The following is a description of a gene set: The process whose specific outcome is the progression of the mesendoderm over time, from its formation to the mature structure. In animal embryos, mesendoderm development gives rise to both mesoderm and endoderm tissues. Mouse Gene Set: GOBP_MESENDODERM_DEVELOPMENT species: Mus musculus, and this is the list of marker genes: Lhx1, Otx2, Ssbp3, Smim43 (NCBI Gene Id 100503068), Foxa2, Smad4, Fgf8 (fibroblast growth factor 8), Eomes, Zfp36l1, Apela, Nodal, Bmpr1a